The following is a description of a gene set: from publication Kitano M, Moriyama S, Ando Y, Hikida M, Mori Y, Kurosaki T, Okada T (PMID 21636294) Human Gene Set: GSE24574_NAIVE_VS_TCONV_CD4_TCELL_UP Genes up-regulated in naïve CD4 Tcells versus T conv cells. We found that a number of Tfh cells downmodulated BCL6 protein after their development, and we sought to compare the gene expression between BCL6-hi Tfh cells and BCL6-low Tfh cells. species: Homo sapiens, and this is the list of marker genes: MAPK3, B4GALT1, OPRK1, RHOB, ARHGAP45, OCM2, SH3PXD2A, CIZ1, ITGA6, RGS9, CASQ2, PIK3IP1 (phosphoinositide-3-kinase interacting protein 1), SYNE1, NMBR, RBM38, RASGRP2, MCF2L, NME3, RGS1, CDX2, IFIH1, SLC2A3, CORO1A, ASIC3, COL14A1 (collagen type XIV alpha 1 chain), PCNX1, OPTN, TXNIP, UBA7, SHOX, DGCR2, PXDC1, LRP10, TUBA1A (NCBI Gene Id 95407), RPS14, SORL1, PBXIP1 (NCBI Gene Id 57326), MCC, CXCR4, JUND, SEC31B, ZFP36L2, ARHGEF11, ZNF101, TOB1, PAPSS2, CDK19, CDH2, PSD (NCBI Gene Id 5662), MRNIP, FOXO4, ITGB2, DLGAP1, DNM3, STARD5, LGMN, MXRA8, CDC14A, NR1H2, SUN2, MAPRE3, SIT1, LGALS3BP, FCMR, FAM168A, PHLDA2, TREX1, CBX4, TPX2 (NCBI Gene Id 23477), PIM1, ITIH4, CYP2D6, CD37, LTB4R (leukotriene B4 receptor), UTRN, MT1H, SERPINF1, HPGD, UBE2C, JOSD1, RPS20 (ribosomal protein S20), DDIT3, RPL36A, BBIP1, H1-10 (NCBI Gene Id 8971), PTX3, TANC2, PNOC, SNAP91, SUOX, GUCY2F, JAK3 (Janus kinase 3), H3C10, SPP2, MYCNOS (MYCN opposite strand), RPS28, TUBB2A, ADAM11, MMP20, COL4A2, PRDM1, PLA2G6, SCN7A, H2AC17, CLK1, MAN2B1, ICAM3, CDC25B, DNAJB1, KCNJ12, VNN2, GLS2, IFITM3, PADI2, MICA, DDIT4, MYO9B, DRD4, MT2A, GADD45B, WWOX, TACR3, SIRPA, ATG13, RASA3, S100A13, HBEGF, IFITM1, PPEF2, HMGB2, MMP16, STMN2, LIMK2, SIK1, HGFAC (HGF activator), PLXNA2, GADD45A, CHD3, TRAF3IP2, PLCD1, BIN1, S1PR4, FCER2, AURKC, ADA, RPL14, CHI3L2, HABP2, MDK, INSL4, MINDY2, SIPA1, ZKSCAN5, NCAPD2, SORBS3, MAN2B2, RPGRIP1L, IL11RA, ERICH1, KLF4, COL21A1 (NCBI Gene Id 81578), MCL1, NUMA1, P2RX5, TNK2, ANXA10, KCNA5, NXPH4 (NCBI Gene Id 11247), ISG20, TRADD, CECR7, ADD3, APOB, IGBP1, CIT, ARHGAP4, ID1, CAV3, DMPK, PHKG2, TLE5, B3GALT4, MTSS1 (NCBI Gene Id 9788), PPM1H, VIPR1 (NCBI Gene Id 9357), FCHO1, SPEG, COL4A1, IZUMO4, ACP5, BTBD2, ACVR2B, GNB2, ACAP1, EREG, BCL11A, GUCA2A, SETD1B, RPL37, TRIB2